Given this list of marker genes DHX38, RPRD2, NONO, DDB1, SFSWAP, ATG12, METAP1, POLR2A, ATXN2L, CNOT2, ABR, PRKCSH, MRPL9, SEC61B, UBN1, CUX1, YWHAZ, ARFGAP2, YWHAQ, MKRN1, JTB, DNPEP, RAF1, FOXJ3, NUP188, AP3S1, CAPZB, HNRNPAB, SUMO2, UBE2D3, HNRNPK, FBXW11, HTATSF1, ZNF410, KDM3B, OTUB1, POLE3, TERF2IP, PWP1, DNAJC8, PRKAG1, HNRNPA2B1 (heterogeneous nuclear ribonucleoprotein A2/B1), HNRNPH2, GMFB, ETF1, HNRNPC, DDX39A, SMNDC1, CLTC, EIF4H, BRD3, ZZZ3, NFATC2IP, TOR1AIP1, XPC, CSNK1G2, DRG1, SEC63 (NCBI Gene Id 55399), XPO6, PABPN1, UBE2I, MORC3 (MORC family CW-type zinc finger 3), GPAA1, IK, RTCB, MRPL28, CTDNEP1, NACA, ILF2, CANX, PRPF8, ZC3H15, NUP62, ATP6V1F, HADHB, PLIN3, STK19, IDH3B, SNRNP200, COX8A, TAF9, TPR, OXA1L, POLR2C, RAC1, COX7A2L, CSNK1D, MFN2, SRRM1, RNF4, TIAL1, DENND4A, IST1, CNBP, SLC25A36, PPP2R5E, CS (citrate synthase), KBTBD2, KHDRBS1, KXD1, PPP2CA, SRRT, NAP1L4, PDAP1, FAM168B, DEK, CAPZA1, RAB1A, SYNCRIP, SUMO1, NELFB, here is a description of the gene set: Human Gene Set: MORF_RAF1 Neighborhood of RAF1 Neighborhood of RAF1 v-raf-1 murine leukemia viral oncogene homolog 1 in the MORF expression compendium species: Homo sapiens